The following is a description of a gene set: species: Homo sapiens The developmental process that results in the creation of defined areas or spaces within the neural plate to which cells respond and eventually are instructed to differentiate. Human Gene Set: GOBP_NEURAL_PLATE_PATTERN_SPECIFICATION, and this is the list of marker genes: FUZ, BMPR1A, PTCH1, CELSR2, SSBP3, OFD1, C2CD3, NOG, TBX18